The following is a description of a gene set: Human Gene Set: MIR7162_3P Genes predicted to be targets of miRBase v22 microRNA hsa-miR-7162-3p in miRDB v6.0 with MirTarget v4 prediction scores > 80 (high confidence targets). from publication Chen Y, Wang X (PMID 31504780) studied in species Homo sapiens, and this is the list of marker genes: SPON2, PUS1, PRMT2, PDS5B, CDK6, DNALI1, PDZD7 (NCBI Gene Id 79955), BTBD10, ANGPT4, RICTOR, PPM1F, ATP2B4, MTMR9, ZNF85 (NCBI Gene Id 7639), MSANTD4, ZFYVE26, COL4A2, ARID3B, ITGA10, SH3RF3, ARHGAP24, GALNT1, WAPL, EGLN2, WDR37, ERCC6, SRSF6, CCND2, MSI2, RNF19A (NCBI Gene Id 81036), IKZF2, CACNA1E, FOXP2, PDSS2, HOXA1, RCN1, GALNT4 (polypeptide N-acetylgalactosaminyltransferase 4), CABLES2, RAB3C, RPRD1B, MTMR12, PRR16, TRIM71, IRS1, SPCS3, TET3, AQP5, KIAA0040, PLXNA4, RB1, MMP1, UHRF2, KLF13, OSMR, SLC37A4, CACNA1I, FNIP1, FGF5, CEP20, SLC46A3, SLC1A4, IDH2, POC1B-GALNT4, FIGNL2, DICER1, FMNL3, ADAM10, ZNF583, TRANK1, SYT1, HIF1AN, CEBPD, ANKFY1, VEPH1, RBFOX1, IGF2BP3, RGS19, SFXN5, RUNX1T1, THAP2, CIAO2A, TAB2, HTRA4, YY1 (YY1 transcription factor), APBB2, CDYL, BEGAIN, DLC1, APOOL, PIK3CA, FOXP1, ZNF322, UTRN, EML1, COL4A6, SYT2, ADAMTS15, ALDH6A1, GPR3, TBC1D7, GCNT4, NKIRAS2, PBX4, SELENOT, SLC25A4, MFAP3L, CASKIN1, TRIM33, ANKRA2, LPP, SLC38A2, HSPA5, ATXN1, XKR8, MLF2 (myeloid leukemia factor 2), NAP1L1, BMPR2, USP44, MTCL2, RAG1, SLC26A9, RBBP4, ARMC8, GNPTAB, NHLH1, FAM43A, HIP1, CRTAP, SH3GL3 (NCBI Gene Id 6457), CFL2, YTHDF3, ITGB3, KLHL6, LRIG2, PAX5, PPARGC1B, THAP1, PANX2, LINC03040, STARD9, LRFN4, CCDC81, UHMK1, ENOX2, MIOS, MYH11, MED6, RBM19, TTC39C, CDV3, PCDHA8, TTLL4, ZDHHC9, LOXL3, ALG2, MARCHF9, B3GNT7, KLK4, PRDM11, RALGPS1, ZNF473, POLR3A, SPECC1, TBKBP1, SBK1, MEF2C, DUSP16, LEPROTL1, ABL2, DET1, SH2B3, IRGQ, RASGRP1 (NCBI Gene Id 10125), ANKRD52, GPCPD1, TRIM15, SRGAP3, PAK3, ANGPTL2, MEST, ZNF695, FIGN, QKI, ACVR2A, PHF20L1, UGGT1, BACH2, ZNF417, UVRAG, GALNT2, SECISBP2L, MFHAS1, PRTG, SENP2, SLC45A4, IKZF3, DPH3, USP3, VAV3, TEF, CEP164, ACVR2B, ALKBH1, SRC, SPRED3, CLOCK (NCBI Gene Id 9575), IGF2BP2, ZBTB10, KRTAP3-2, WIPI1, RAMAC, PSG7, RBMS1, STXBP5, ACER2, SLC19A3, CYRIA, PSMB2